The following is a description of a gene set: Abnormal pleura morphology An abnormality of the pulmonary pleura, the thin, transparent membrane which covers the lungs and lines the inside of the chest walls. studied in species Homo sapiens Human Gene Set: HP_ABNORMAL_PLEURA_MORPHOLOGY, and this is the list of marker genes: SEMA4D, GPR35, TSC2, STAT6, FBLN5, SPP1 (NCBI Gene Id 6696), ADAMTS3, NOD2 (nucleotide binding oligomerization domain containing 2), CFH, SOX18, BCL2, TGFB3, SFTPC, FOXC2, SMAD2, LAMB3 (laminin subunit beta 3), HMOX1, CLPB (NCBI Gene Id 81570), STAT4, TGFBR1 (transforming growth factor beta receptor 1), LACC1, DDR2, CD46, ABCA3, DZIP1L (DAZ interacting zinc finger protein 1 like), SLC25A24, SCN4A, TREX1, NR1H4, NAB2, KLRC4, BTNL2, PRDM10, IRF4, IL6, SEC61A1, CALCRL, PTPN11, HFE (NCBI Gene Id 3077), BMP2, SERPINF2, KCNN4, SLC6A14, ZNFX1, MAT2A, CFI, SLC11A1, PTPN22, EIF2AK4, SFTPB, UBAC2, CCND1, TGFB1, BRAF, IPO8, LAMA3, ITK, CEACAM6, RIT1, DSE, ADAMTS2, HEY2, MAP2K1, LOX, PLVAP, TNFRSF1A, IFIH1, CBL, EDNRA, ACTA2, KIF11, MTO1, ERAP1, IRAK1, TNFRSF1B, CYBC1, MDFIC, TAPT1, CCBE1, CARD10, TGFB2, MYH11, SMAD3 (NCBI Gene Id 51521), B3GALT6, TLR4 (toll like receptor 4), LAMC2, FCGR2A, IKZF1, IL12A, CTRC, COL3A1, ACTA1, MYD88, ELP1, RASA1, PRKAG2, TSC1, SPINK1, THSD4, CLCA4, EXT1, TCF4, HLA-DPB1, MYLK, FOXE3, FAS, CTLA4, MST1 (NCBI Gene Id 4485), PIEZO1, SERPINA1, NRAS, C4A (NCBI Gene Id 720), ELN, FSHR, CEACAM3, GCLC, DNASE1, CFTR, PKHD1, HLA-DPA1, USP18, PRTN3, FAT4, FCGR2B, CCR1, IL10, STAT3, GAA, MEFV, DNASE1L3, IL23R, MFAP5, CHST14, P4HA2, PRSS1, CCR2, AGR2, SLC31A1, LZTR1, TGFBR2, FBN1, IL12A-AS1, HLA-B, HELLPAR, KEAP1, CAV1, SCARB2, ATP6V1E1, SMAD4, STX1A, GSTM3, RAI1, PRKG1, EXT2, EPHB4, VPS51, FBXO11, FLCN, BAP1, DCTN4, DICER1, EFEMP2, ABL1, LTBP1, WARS2, GUSB, ENG, BCL6, CD28, MIF, DEF6, HLA-DRB1, BLTP1, IFNGR1, ACTN4, PRG4, SLC9A3, HRAS, SAT1, GPKOW, SLC26A9, FOXF1, SLC34A2, PRSS2, TXNDC15, ALG14, CYBB, LYST